Given this list of marker genes FADD, PPP1CB, SP3, RAB5A, USP8 (ubiquitin specific peptidase 8), TGFB3, ATF2, PPP1CA, KIT, KRT6A, GADD45A, CAST, BCL2A1, TCF12, here is a description of the gene set: Arsenic compounds are widely distributed and arsenic ingestion is associated with many human diseases, including blackfoot disease, atherosclerosis, and cancers. However, the underlying mechanism of arsenic toxicity is not understood. In human fibroblast cells (HFW), arsenite is known to induce oxidative damage, chromosome aberrations, cell cycle arrest, and aneuploidy, and the manifestation of these cellular responses is dependent on changes in gene expression which can be analyzed using the cDNA microarray technique. In this study, cDNA microarray membranes with 568 human genes were used to examine mRNA profile changes in HFW cells treated for 0 to 24 h with 5 microM sodium arsenite. On the basis of the mean value for three independent experiments, 133 target genes were selected for a 2 x 3 self-organizing map cluster analysis; 94 were found to be induced by arsenite treatment, whereas 39 were repressed. These genes were categorized as signal transduction, transcriptional regulation, cell cycle control, stress responses, proteolytic enzymes, and miscellaneous. Significant changes in the signaling-related and transcriptional regulation genes indicated that arsenite induces complex toxicopathological injury. Genes in cluster 2: moderately up-regulated in HFW cells (fibroblast) upon treatment with sodium arsenite at all time points. studied in species Homo sapiens Human Gene Set: YIH_RESPONSE_TO_ARSENITE_C2 from publication Yih LH, Peck K, Lee TC (PMID 12016162)